Given this list of marker genes Septin2, Slc1a2, Slc7a1, Grm1, Agt, Gfap, Rgs4, Psen1, Slc7a8, Slc7a3, Slc6a20a, Slc43a2, Slc1a6, Slc38a3, Slc7a2, Slc38a4, Slc38a2, Slc47a1, Slc1a1, Slc16a2, Arl6ip1, Slc43a1, Slc1a5, Slc6a9, Per2, Itgb1, Slc17a8, Slc22a2, Slc1a3, Slc1a4 (solute carrier family 1 (glutamate/neutral amino acid transporter), member 4), Slc3a2, Slc6a20b, Arg2, Arhgef11, Slc6a6, Slc7a5, Slc36a2, Slc36a1, Tnf, Cltrn, Tspo2, Prkcd, Slc6a13, Ntsr1, Slc7a11, Arl6ip5, Kcnj10, Slc6a14, Slc6a5, Cln8, Ace2, Slc38a1, Slc22a4, Rgs2, Arg1, Slc38a5, Slc6a7, here is a description of the gene set: Mouse Gene Set: GOBP_AMINO_ACID_IMPORT_ACROSS_PLASMA_MEMBRANE studied in species Mus musculus The directed movement of an amino acid from outside of a cell, across the plasma membrane and into the cytosol.